The following is a description of a gene set: p75NTR can also form a receptor complex with the Nogo receptor (NgR). Such complexes mediates axonal outgrowth inhibitory signals of MDGIs (myelin-derived growth-inhibitors), such as Nogo66, myelin-associated glycoprotein (MAG), and oligodendrocyte myelin glycoprotein (OMGP). part of: p75NTR regulates axonogenesis studied in species Homo sapiens Reactome Pathway: Axonal growth inhibition (RHOA activation), and this is the list of marker genes: LINGO1, RTN4R, RTN4, RHOA, MCF2, ARHGDIA, OMG, MAG, NGFR